Given this list of marker genes LALBA, NQO1, AKAP7, PSAP, EYA2, ARFGAP3, KRT1, ARID3B, HOXA3, EIF4H, MYL6, TCF20, SYT9, GABBR1, RAB5B, KCNH2, RAB33B, RCVRN, HRH2, GUCA1A, PCSK7, MX1, NAGA, SNX13, GNG3, GREM2, NCOA3, F3, ELMOD3, CLTB, JARID2, RANBP10, SH3GL1, CNTRL, ST3GAL1, HIP1R, BCL6, PHRF1, ABCD1, INPP5K, AKIRIN1, USP2, RAB17, FGD3, MAP4K3, ARF3, TRAF2, TFPI2, EXOC7, PEA15, DIAPH1, WBP1, TRAPPC14, ULK2, REXO1, F9, SOX4, PLEKHB2, PRCC, UCK1, APOBEC1, CXCR4, SH3BP1, BTC, FBXW4, MYO1F, MAP1LC3A (NCBI Gene Id 84557), MFGE8, CFH, MCOLN2, PPFIBP2, BRAP, MROH1, KRT7, PHF1, CYTH3, SPPL2B, RPL22, RECQL, POMC, HGF, ADRB2, ACTR1B, NRTN, GRIA3, RFXANK, SPSB1, NECAP1, RALGPS2, RPS6KA2, KIF3C, UBE2E3 (ubiquitin conjugating enzyme E2 E3), SUGP2, PDE4B, SEC11C, GBF1 (NCBI Gene Id 8729), CCKBR, FRMD8, ZYG11B, BSDC1, PRDM5, NEDD4L, ACOT8, HES2, TLE4, DENND2B, TIMP2, ACVRL1, TEC, CANT1, COL6A2, RECK, CELA2A, IP6K1 (NCBI Gene Id 9807), TBC1D20, ATP9A, ZBTB20, FOXK1, PGLYRP1 (NCBI Gene Id 8993), ABCG1, RAPGEF4, MAP7, CA2, AGXT, TNNC2, HCFC1R1, MYH7, SEMA4F, COQ10A, ARHGEF25 (NCBI Gene Id 115557), CLIP2 (CAP-Gly domain containing linker protein 2), ASGR2, MAPK8IP3, DNAJB4, RBM4B, TRIM13, SPINK4, SLFN12, OSBPL5, CYP2E1, APP, DLGAP4, USP3, CCDC152, TCN2, CD1D, LHCGR, SQOR, BRWD3, ADGRG3, PKP3, MAP2K6, IKZF2, SPA17, UNC119, USF2, CEL, LGALS4, HLA-DOA, RFX2, PKD1, SLC39A4, MTFR1L, PLEKHA5, SURF4, BCL2, CTNNAL1, QSOX1, HCRT, SYNRG, WNT11, PMPCA (peptidase, mitochondrial processing subunit alpha), RETREG2 (reticulophagy regulator family member 2), SLC22A1, PAPSS2 (NCBI Gene Id 9060), SPATA6, CD79B, IL3RA, ADGRL1, CYP3A43, DLX1, YJU2, F2RL1, COLQ, BLOC1S1, FBXO6, EEF1A2, GRINA, STAT5A, B4GALT1, RPL12, RGS3, SIT1, HR, INSM1, UBXN6, MSL2, SIAH1, PI4K2A, RPL37A, here is a description of the gene set: species: Homo sapiens from publication Agarwal P, Raghavan A, Nandiwada SL, Curtsinger JM, Bohjanen PR, Mueller DL, Mescher MF (PMID 19592655) Human Gene Set: GSE15930_NAIVE_VS_24H_IN_VITRO_STIM_INFAB_CD8_TCELL_UP Genes up-regulated in comparison of CD8 T cells at 0 h versus those at 24 h after stimulation with antigen-B7-1. Differentiation of naive CD8 T cells into cytotoxic effector cells requires three distinct signals- antigen (signal 1), costimulation -B7-1 (signal 2) and cytokine, either interleukin-12 or interferon-a/b (signal 3). Interaction of naive CD8 T cells with antigen and B7-1 programs cell division and proliferation whereas the presence of cytokines- IL-12 or IFNa/b promote survival, differentiation and memory establishment. In the absence of signal 3, the cells interacting with antigen/B7-1 undergo tolerance induction. The objective of this study was to elucidate the mechanisms how the provision of signal 3 promotes differentiation and averts tolerance induction in CD8 T cells. Trichostatin A is a pharmacological agent that inhibits histone deacetylase activity, hence regulating chromatin structure and gene expression and differentiation in many cell types. Gene signature profiles of IL-12, IFNa/b and trichostatin A stimulated cells were compared to elucidate the molecular mechanisms of gene regulation. Oligonucleotide microarray analysis is carried out to determine the extent and molecular nature of the CD8 T cell differentiation program induced by IL-12 or IFNa/b in concert with antigen and B7-1 signal.